Given this list of marker genes BTRC, SLC10A2, ABHD13, LUZP4, PIK3R2, ANO1, SEPTIN3, MRPL9, CNTN1, EIF4E2, VPS36, ADGRL2, NFYA, SEMA4G, PAG1, CHAF1B, MOCS2, MECP2, ZCCHC14, ARID4A, ATF6B, ATP11AUN, SNX20, CELF5, SRGN, BRPF3, WSB1 (WD repeat and SOCS box containing 1), HMGN3, MIS18A, HIP1, SERPINE1, CAMKK2, SOX6, NAT8L, VPS53, MORN4, COP1, SUCO, STK32A, CPEB2, MEX3C, FANCC, PIK3R1, PLCL1, LINC02873, TMTC1, ATF7IP, PDE7A, CYP24A1, DDX20, KLHL42 (NCBI Gene Id 57542), CDH7, NUCKS1, OLR1 (NCBI Gene Id 4973), RESF1 (NCBI Gene Id 55196), IRAK4, CACUL1, CEMIP2, here is a description of the gene set: studied in species Homo sapiens from publication Chen Y, Wang X (PMID 31504780) Human Gene Set: MIR4433B_5P Genes predicted to be targets of miRBase v22 microRNA hsa-miR-4433b-5p in miRDB v6.0 with MirTarget v4 prediction scores > 80 (high confidence targets).